Given this list of marker genes FZD3, CLDN17, PIK3CD, CLDN7, RAF1, COL4A5, TGFB3, PIK3R2, AKT3, NUBPL, GRB2, WNT10A, EIF5A2, CLDN24, MMP2, FMNL2, TUSC3, CLDN18 (claudin 18), SHC1 (SHC adaptor protein 1), PROX1 (prospero homeobox 1), FZD9 (NCBI Gene Id 8326), MAPK14, MMP9 (NCBI Gene Id 4318), WNT3, MAPK1 (NCBI Gene Id 5594), PIK3CB, PKP2, AKT1, FZD6, CLDN6, WNT10B, FZD1, ZEB1, MMP15, ID1, MAP2K2, SMAD4, TJP1, SMAD2, CDKL2, WNT5B, FOXM1, CLDN9, ITGA5, CLDN20, TGFB1, COL4A4, DLL1, FOXQ1, COL4A3, MAPK11, HIF1A, MAP2K6, KRAS, PDCD6, NR2C2, TWIST1, TMPRSS4, WNT9B, MAP2K4, WNT5A (NCBI Gene Id 7474, Wnt family member 5A), CLDN23, NRP2, CLDN16, TWIST2, WNT16, CLDN12, DSP, PIK3CA, WNT3A, CLDN5, PKP1, EZH2, PIK3R1, SOS1, HRAS, OCLN, MEF2D, MAPK3, CTDSP1, JAG2, NOTCH2, CLDN10, ID2, MAP2K3, CLDN15, ZEB2, CLDN19 (NCBI Gene Id 30063), WNT2, LATS2, CLDN4, NOTCH4 (NCBI Gene Id 4855), COL4A2, NOTCH1, PALS1, EED, TGFBR2, SNAI2, SPARC, FZD7, SOS2, COL4A6, MIR9-2, MAPK8, CLDN8, WNT2B, MAPK12, VTN, TRAF6, WNT6, CRB3, LRP6, JAG1, CLDN14, STRAP, GSK3B, DLK1, FZD8, CDH1, CLDN3, CLDN22, WNT11, FZD10, DLL4, WNT7A, CLDN1, FZD4, WNT8A, RBBP4, TGFB2, WNT7B, SUZ12, MAPK13, FN1, TGFBR1, CLDN11, AKT2, GDF15, DLL3, CLDN2, FOXC2, RBPJ, MAP2K1, PIK3R3, CTNNB1, WNT4 (Wnt family member 4), COL4A1, WNT1, PAK1, LRP5, FZD5, FZD2, WNT9A, PKD1, NOTCH3, SNAI1, WNT8B, JUP, TP53, SMAD3, CDH2, here is a description of the gene set: studied in species Homo sapiens Human Gene Set: WP_EPITHELIAL_TO_MESENCHYMAL_TRANSITION_IN_COLORECTAL_CANCER Epithelial to mesenchymal transition in colorectal cancer